Given this list of marker genes HOXA5, HMGN5, OGFOD3, TXNIP, WRAP73, NFE2L2, STAG2, EGFL6, LINC02637 (NCBI Gene Id 102724350), PKN2, TFDP2, SSX2IP, RAD51, TLK1, TBC1D17, EMC9, MAP2K4, SSX4, TRPM8, KPNA4 (karyopherin subunit alpha 4), MAP6D1, B4GALT4 (NCBI Gene Id 8702), EML2, DPY19L2P2, HSD17B4, HOXB2, CAT, CENPQ, METAP2, SUN1, CDK5R1, DST, DZIP3, RSRC1, ACP2, MSH3, HFE, TMT1A, PKNOX1, MLLT10, ZMYM2, WWP1, CTBP2 (NCBI Gene Id 87435), HOXA6, HOXA10, HOXB3, AHI1, ARIH2, MACIR, PPARGC1A, LHFPL6, CAPRIN2, RCE1, MAN2A2, ZNF768, RAD1, TVP23B, BMPR1A, LUZP4, GP5, CACNA2D1, UBE2K, GNRHR, PDE3A, ZFR2 (zinc finger RNA binding protein 2), COL4A5, SOX13, IQCE, SH3GL1, MBNL2, COMMD4, ZFAND6, SPDL1, AMN, RGSL1, ZXDC, PPP1R26, TANK, GPR137B, GK, AKAP12, RBM5, CFD, DHFR, PAIP1, RYBP, NCAM2, RESF1, LGR4, CETN1, NIPBL, CSTF1, PAK1IP1, UGGT1, MTX2, KYNU, RTL8C, RER1, NEK7, RAB38, PBX3, HOXB6, HSP90AA1, SMC4, CYB5RL, ALK, MCHR1, SLC39A1, MEIS1, CTH, AP5Z1, MYO1C, PLPPR3, PRKAB1 (protein kinase AMP-activated non-catalytic subunit beta 1), ASRGL1, PDS5B, HOXA9, PLCB3, LIMS1 (NCBI Gene Id 3987), CACNA1I, ORC6, HNRNPH3, TST, CRP, ACO1, HOXA7, CARD9, CEP135, DCK, SPG7, here is a description of the gene set: Somatic mutations in nucleophosmin (NPM1) occur in approximately 35% of adult acute myeloid leukemia (AML). To assess the frequency of NPM1 mutations in pediatric AML, we sequenced NPM1 in the diagnostic blasts from 93 pediatric AML patients. Six cases harbored NPM1 mutations, with each case lacking common cytogenetic abnormalities. To explore the phenotype of the AMLs with NPM1 mutations, gene expression profiles were obtained using Affymetrix U133A microarrays. NPM1 mutations were associated with increased expression of multiple homeobox genes including HOXA9, A10, B2, B6 and MEIS1. As dysregulated homeobox gene expression is also a feature of MLL-rearranged leukemia, the gene expression signatures of NPM1-mutated and MLL-rearranged leukemias were compared. Significant differences were identified between these leukemia subtypes including the expression of different HOX genes, with NPM1-mutated AML showing higher levels of expression of HOXB2, B3, B6 and D4. These results confirm recent reports of perturbed HOX expression in NPM1-mutated adult AML, and provide the first evidence that the NPM1-mutated signature is distinct from MLL-rearranged AML. These findings suggest that mutated NPM1 leads to dysregulated HOX expression via a different mechanism than MLL rearrangement. The 'NPM1-mutated signature 2': genes up-regulated in pediatric AML (acute myeloid leukemia) samples with mutated NPM1 compared to the AML cases with the intact gene and without recurring cytogenetic anomalities or M7 phenotype. species: Homo sapiens Human Gene Set: MULLIGHAN_NPM1_MUTATED_SIGNATURE_2_UP from publication Mullighan CG, Kennedy A, Zhou X, Radtke I, Phillips LA, Shurtleff SA, Downing JR (PMID 17597811)